The following is a description of a gene set: Human Gene Set: chr4q34 species: Homo sapiens, and this is the list of marker genes: TENM3, TSEN2P1, RPL5P11, HPGD, HAFML, AGA-DT, LINC02500, ADAM29, LINC02504, ENSG00000301059, LINC02509, HAND2, MIR4276, GALNT7-DT (GALNT7 divergent transcript), LINC02269, LINC01098 (long intergenic non-protein coding RNA 1098), LINC02268, LINC00290, MIR6082, GPM6A-DT, ENSG00000251216, FBXO8, AGA, SPCS3-AS1, ENSG00000294364, CCNHP1, RN7SL253P, MORF4, GALNT7, CEP44, HAND2-AS1, NEIL3, SAP30, RNA5SP172, RN7SKP13, SPATA4, ADAM20P2, WDR17, RNU1-45P, MIR1305, RN7SKP136, ENSG00000287544, MARK2P4, MIR548T, ENSG00000212191, ENSG00000302337, ASB5, LINC01099, ENSG00000287775, SCRG1, RNA5SP173, VEGFC, SPCS3, TENM3-AS1, LINC02174, NDUFB5P1, GPM6A, HMGB2, GALNTL6, LINC02431, RANP6, GLRA3, SAP30-DT, RNU6-1096P